Given this list of marker genes DHFR, CFAP126, SEC61A2, NEK5, CIAO1, TUBB4B, ISM1, STIL, CLHC1, EML1, IFT27 (intraflagellar transport 27), RFX2, ANKS1A, ARL4C, IFT57, DNAAF4, RALGPS1, SMIM34, SAXO4, PSMG3-AS1, CRY1, CDK5R1, CFAP206, CCDC121, ABHD6, TMEM231, JHY, LCA5L (lebercilin LCA5 like), MST1, TMEM121, NAA38, PASK, PURA, TRAF3, PRPS2, MDM2 (NCBI Gene Id 84825), IFT56, LZTFL1, DNAJB13, ARL6, DDX25, DNAL4, NPHP1 (nephrocystin 1), ODF2, FAM181B, PCM1, SAXO2, CEP41, CFAP107, TCF7, AKAP14, LRRC23, CFAP300, FAM149A, PSME2, ZNFX1, GLIPR2, HYLS1, MDH1B, CFAP95, CEP112, SPEF2, MEIG1, FOXN4, TYRO3, CFAP70, PPIL6, ENSG00000255367, RASSF1, ARMC2, IFT52, CFAP57, LRP2BP (LRP2 binding protein), CFAP91, LHX2, DNAL1, CFAP46, COG7, SLC31A2, TRIM24, RAB36, TPPP3, TBC1D31, COCH, NPHP4 (NCBI Gene Id 261734), CACUL1, CARINH, CCDC87, C11orf16, SLC4A8, FAM163A, OASL, CEP350, SHROOM2, LRRC46, C16orf46, ST7, DNAH11, CCDC65, THBS3-AS1, ELOA-AS1, B4GAT1, AGBL2, ABLIM2, TUB, AGO2, CEP70, ERCC1, CAMSAP1, DUSP19, DNAI1, CYB5D1, EFHB, C5AR1, NPTX2, TOGARAM2, RANBP9, NOD2, TTLL6, KIAA1549, SDHA, EPOR, ABITRAM, CFAP45, ZBBX (NCBI Gene Id 79740), DNAH5, TAFA2, E2F7, CEP85, MICOS10, EFHC1, TTC21A, ZFP36L2, SAYSD1, IQCK, ZNF271P, GSKIP, HECTD1, CIMAP3, RNF32, HEATR3, CRACDL, CPLANE1, ZMYND10, CFAP52, EFCAB12, CIMIP5, TTC7B, WDR49, MELTF, RPGRIP1L, WRAP73, TTC29, TMEM106C, FBXL13, ZNF606, DNAAF3, DNAJC9-AS1, RNF182 (NCBI Gene Id 221687), HAGLR, GBP1, NGRN, OTUD4, AK7, LRRC27, CDKL3, FAM81B, PCSK6, AK9, CCDC89 (NCBI Gene Id 220388), SANBR, DNAAF1, TMEM232, REV3L, LRRK1, TEKT2, KCNE1, SPA17, USP32 (NCBI Gene Id 84669), TP73, CFAP119, JAZF1, RFX3, PKIG, THORLNC, DNALI1, ACTR6, CCDC74A, C2orf74-AS1, FAM229B, DNAI3, RSPH1, NRAV, CAPS2, ZNF599, DPY19L2P2, KIF3A, STRBP, API5, CFAP92, KIF9 (NCBI Gene Id 64147), RIBC1 (RIB43A domain with coiled-coils 1), MYH10, UNC119B, CFAP43, PIERCE1, DNAI7, SPATA33, KIF24, FBXO15, CCT6B, IFIT2, SLC25A14, PHF10, MDM1, NEK4, AKNA, TBC1D24, BBOF1, ADGB, PFN2, MRNIP-DT, CYTH3, LINC01128, DNAAF10, CFAP298, SCARA3, ATP9B, ZNF200, CCP110, GON7, AZU1, STOX1, SLC20A1-DT, DNAH7, OTUD7B, NUDC, SMIM15-AS1, SERPINI2, CCDC138, IFT22, PTPN22, MOK, SRP68, LINC03086, ZBTB21, C8orf48, BBS5, DNAH12, LINC01588, SLC41A1, EFCAB2, PSIP1, CIPC (NCBI Gene Id 85457), CFAP263, CMPK2, MSL3, ZNF497-AS1, ARMC3, IFT81, RMI1, LRRC10B, IFT70A, C16orf54, AIFM2, DCTN2 (NCBI Gene Id 1640), SUZ12, CFAP69, ARHGEF4, NME5, DZIP1, LY6H, POC1A, GPATCH2L, IK, SRI, DZANK1, CFAP157, RAB9B, PHOSPHO2, FSD1L, DNAH6, ZC2HC1C, WDR38, KLHL41, ZHX3, GPM6B, PITPNM1, GPX8, IFT74, MORN2, CFAP36, BAIAP2-DT, ENDOG, CDK2AP2, SPEF1, HES6, COPRS, BMAL2, ODF2L, PAQR8, KIF6, INSIG1-DT, TSPAN2, ARHGAP39 (NCBI Gene Id 80728), IQCH, TMEM67, RSPH4A, CAMK2G, RIBC2, SHANK2, HSP90AA1, MIR646HG, TEKT1, TRIM22, LINGO1, LRWD1, DRAIC, SPOP, RHEBL1, LRRC49, P4HTM, AIG1 (NCBI Gene Id 51638), SPMIP6, NACC2, PNMA1, NIPSNAP3B, TXLNA, STPG1, RAB15, CDKN2D, TMCC1, CNTRL, EFCAB6, DENND6B, CCDC78, NCBP3, EML6, RSPH9, PPM1E, POMT1, FANK1 (fibronectin type III and ankyrin repeat domains 1), ENSG00000291006, CEP78, CFAP299, CLBA1, CEP19, MYCL, RPGR, TUBG1, CDK20, RINT1, BBS12 (NCBI Gene Id 166379), ZNF346, ODAD1, RSAD2, ROPN1L, ZNF20, NEK11, DNAAF6, CCDC40, GAPVD1, SNTN, MIR548N, NETO2, MAP3K2-DT, XAF1, GOLGA2P5, GIHCG, CEP120, CETN2, GPR107, MUC12, IFT70B, SPATA6, MLF1 (NCBI Gene Id 4291), COPB2-DT, PSMB8-AS1, CYP2U1, RADIL, MORN5 (NCBI Gene Id 254956), TTC12, CFAP20DC, CLUAP1, RASAL2, APOLD1, DYNLRB2, WDPCP, PLK4, TOGARAM1, DPCD, FRMD8, BLTP3A, DNAI4, PAQR4, NEK2, GPR137B, FCHSD2, IFT43, ZNF432, CAPSL, CCDC39, CCDC30, CABCOCO1, PIH1D2, ZBTB25, KLHDC9, ODAD2, BRD3OS, CFAP53, EMC3, H2AC11, PPP6R3, CFAP221, MKX, ISCA2, CEP128, MACROH2A1, STON2, CFAP251, CFAP210, MAP3K19, SNHG10, SRGAP3, AK8, ODAD4, IQUB, NGEF, VDAC3, MAP6, SAMD15, CDC20B, C7orf57, ENKUR, HMOX1, USP13, CFAP20, LRTOMT, MAK, ERCC4, EFHC2, H3-3A, MIR449A, DNAJC27, CFAP184, RABL2B, RSPH14, MELTF-AS1, REEP1, CEP43, CCDC191, DRC3, CC2D2A, DRC1, ZNF295-AS1, CFAP276, PAXIP1-DT, PRR29, LIAT1, CFAP96, SPACA9, FOXJ1, CAPS, CCNO (cyclin O), CFAP90, SPATA17, IQCG, PHF7, CHRM4, HERC2, SPATS2, PHTF1, IFTAP, ZFAND4, MTF1, TSGA10, here is a description of the gene set: The effectiveness of therapies targeting specific pathways in breast cancer, such as the estrogen receptor or HER2, is limited because many tumors manifest resistance, either de novo or acquired, during the course of treatment. To investigate molecular mechanisms of resistance, we used two xenograft models of estrogen receptor-positive (ER+) breast cancer, one with and one without HER2 overexpression (MCF7/HER2-18 and MCF7 wt, respectively). Mice with established tumors were assigned to the following treatment groups: estrogen supplementation (E2), estrogen deprivation (ED), ED plus tamoxifen (Tam), all with or without the epidermal growth factor receptor tyrosine kinase inhibitor gefitinib (G). Another group received ED plus the antiestrogen fulvestrant (MCF7 wt only). Tumors with acquired or de novo resistance to these endocrine therapies were profiled for gene expression and compared with tumors in the E2 control group. One class of genes underexpressed in endocrine-resistant tumors (relative to E2-treated tumors) were estrogen inducible in vitro and associated with ER+ human breast cancers (luminal subtype). Another class of genes overexpressed in tumors with acquired resistance in both models represented transcriptional targets of HER2 signaling and was associated with ER-/HER2+ human cancers (ERBB2+ subtype). A third class of genes overexpressed in MCF7/HER2-18 tumors exhibiting de novo resistance to tamoxifen was associated with ER+ human cancers but not with estrogen-regulated genes. Thus, in response to various endocrine therapy regimens, these xenograft breast tumors shut down classic estrogen signaling and activate alternative pathways such as HER2 that contribute to treatment resistance. Over time, the molecular phenotype of breast cancer can change. studied in species Homo sapiens Human Gene Set: CREIGHTON_ENDOCRINE_THERAPY_RESISTANCE_2 The 'group 2 set' of genes associated with acquired endocrine therapy resistance in breast tumors expressing ESR1 and ERBB2. from publication Creighton CJ, Massarweh S, Huang S, Tsimelzon A, Hilsenbeck SG, Osborne CK, Shou J, Malorni L, Schiff R (PMID 18794137)